The following is a description of a gene set: Human Gene Set: REACTOME_REGULATION_OF_PTEN_LOCALIZATION Regulation of PTEN localization studied in species Homo sapiens, and this is the list of marker genes: UBC, USP7, PML (NCBI Gene Id 5371), PTEN, UBA52 (NCBI Gene Id 7311), XIAP, NEDD4, RPS27A, UBB